Given this list of marker genes Tcf7, Hoxa13 (NCBI Gene Id 15398), Tcf7l2, Gli3, Ift172, Filip1l, Hoxd13, Wnt5a, Dact1 (dishevelled-binding antagonist of beta-catenin 1), Gli2, Shh, here is a description of the gene set: studied in species Mus musculus The process whose specific outcome is the progression of the hindgut over time, from its formation to the mature structure. The hindgut is part of the alimentary canal that lies posterior to the midgut. Mouse Gene Set: GOBP_HINDGUT_DEVELOPMENT